Given this list of marker genes BAK1, CASP1, DAXX, NAIP, CFLAR, TNFRSF17, PARN, TNFRSF12A, SERPINB9, here is a description of the gene set: Mutation of the genes encoding the WNT signaling components adenomatous polyposis coli or beta-catenin plays a critical role in the initiation of colorectal cancer. These mutations cause constitutively active beta-catenin/TCF-mediated transcription, driving the transformation of intestinal crypts to colorectal cancer precursor lesions, called dysplastic aberrant crypt foci. CD44 is a prominent WNT signaling target in the intestine and is selectively expressed on the renewing epithelial cells lining the crypts. The expression of CD44 is dramatically increased in aberrant crypt foci in both humans and tumor-susceptible Apc(Min/+) mice, suggesting a role for CD44 in intestinal tumorigenesis. To study this role, we crossed C57BL/6J-Cd44(-/-) mice with C57BL/6J-Apc(Min/+) mice. Compared with C57BL/6J-Cd44(+/+)/Apc(Min/+) mice, C57BL/6J-Cd44(-/-)/Apc(Min/+) mice showed an almost 50% reduction in the number of intestinal adenomas. This reduction was primarily caused by a decrease in the formation of aberrant crypts, implying the involvement of CD44 in tumor initiation. The absence of CD44 in the normal (nonneoplastic) crypts of Cd44(-/-)/Apc(Min/+) mice did not alter the proliferative capacity and size of the intestinal stem cell and transit-amplifying compartments. However, compared with Cd44(+/+)/Apc(Min/+) mice, Cd44(-/-)/Apc(Min/+) showed an increase in the number of apoptotic epithelial cells at the base of the crypt which correlated with an increased expression of the proapoptotic genes Bok and Dr6. Our results show an important role for CD44 in intestinal tumorigenesis and suggest that CD44 does not affect proliferation but is involved in the control of the balance between survival and apoptosis in the intestinal crypt. studied in species Mus musculus from publication Zeilstra J, Joosten SP, Dokter M, Verwiel E, Spaargaren M, Pals ST (PMID 18483247) Genes implicated in apoptosis that were down-regulated in duodenum of CD44 knockout mice. Human Gene Set: ZEILSTRA_CD44_TARGETS_DN